The following is a description of a gene set: Any process that modulates the frequency, rate or extent of the covalent alteration of one or more amino acid residues within a protein. Mouse Gene Set: GOBP_REGULATION_OF_PROTEIN_MODIFICATION_PROCESS species: Mus musculus, and this is the list of marker genes: Unc119, Ppia, Smpd3, Slc51b (solute carrier family 51, beta subunit), Bcl2, Cdk2ap1, Lats1, Cdkn1c, Mgat4d, Mapkap1, Garem1, Sh3gl2, Firrm, Ifnar1, Tnik, Atg101, Sez6l2, Nod2 (nucleotide-binding oligomerization domain containing 2), Akap6 (NCBI Gene Id 238161), Gtpbp4, Parp14, Plxnb2, Gstp3, Rabgef1, Fgf18, Pkib, Inpp5k, Lep, Nf2, Camp, Eif2ak3, Snta1, Irgm2, Jak2, Cblc, Fgf4, Prkrip1, Akt1, Abi1, Abca2, Trib2, Cd40, Sfn, Pias1, Rock2, Fam107a, Cdkn2a, Wnk4, Dnajb2, Itch, Adcy8, Pik3r5, Map3k10, Cln3, Prmt3, Tnfrsf18, Tab2, Arhgef2, Ripk3, Gstp1, Egf, Oprd1, Inhba, Ahrr, Pin1, Fiz1, Pkig, Hmga2, Wnk3, Fgf1, Drd2, Rgn, C3, Thbs4, Slc1a1, Epha7, Areg, Fnip2, Ticam1, Ube2v1, Ptpn11, Prickle1, Traf4, Trim44, Pik3r3, Ptpn6, Itgb2l, Cdk12, Arrdc4, Ccnd1, Prkaa1, Il3, Rgs2, Tlr8, Ddx3x (DEAD box helicase 3, X-linked), Gnas, Psen1, Atg13, Hif1a, Kndc1, Cd6, Dnaja1, Cck, Sptbn4, Ceacam1, Plec, Spsb4, Ptgis, Bag5, Wdr24, Bmp2, Gprc5b, Traf3ip1, Hsp90aa1, Peli3, Adra2a, Tlr6, Gps2, Pdcd10, Rab3gap2, Rap2a, Bcar3, Il21, Itln1, Ep300, Adam9, Spn, Tsacc, Casp3, Hyal2, Sh2d1b2, Bag1 (BCL2-associated athanogene 1), Gstp2, Fbxo4, Lrp4, Cspg4 (chondroitin sulfate proteoglycan 4), Dcun1d4, Cib1, Cab39, Hgs, Camkk2, Pard3, Ube2srt (NCBI Gene Id 620508), Cdc37, Stk38, Ptpn13, Cntn1, Cblb, Flt4, Ptprh, Tnfrsf1a, Mir26a-2, Trib3, Epha1, Il13, Bag2, Psen2, Mob2, Dusp10, Magi3, G6pd2, Pip5kl1, Nbn, Snx9, Fn1, Fanci, Ctnnb1, Hnf4a, Ppargc1a, Peli2, Fzr1, Il23a (interleukin 23, alpha subunit p19), Card14, Kdr (NCBI Gene Id 269657), Fbln1 (fibulin 1), Dtx3l, Bmpr2 (bone morphogenetic protein receptor type 2), Ivns1abp (influenza virus NS1A binding protein), Hes1, Tlr4, Gpr39, Macroh2a1, Smg8, Taok1, Fancm, Sesn2, Mlst8, Cd80, Flt1, Lime1, Hes5, Tab1, Ccl5, Itgb2, Cry1, Apoe, Tsc2, Irak1, Rassf5, Tnfsf18, Yeats2, Limch1, Tesk1, Ect2, Tnks1bp1, Dnajc3, Gab1, Blvra, Cenpe, Ins2, Ube2d1, Dip2b, Zfyve28, C9orf72, Bex6, Bccip, Drd4, Vtn, Bmi1, Mad2l2, Thbs1, Spatc1l, Rad50, Htr2b, Wdfy2, Prkar1a, Pttg1ip, Ptpn2, Hamp, Adrb2, Chfr, Ucn, Nf1, Thy1, Ube3a, Psrc1, Pdgfra, Axin2, Spdye4a, Stil, Fbxw7, Emp2, Ang5, Cadm1, Rap2b, Wdr48, Sox4, Vegfc, Aplp2, Laptm5, Gper1, D1Pas1, Ccl19-ps3, Ralb, Hsf1, Usp44, Cdkn2d, Chi3l1, Mmp9, Map2k4, Pdgfa, Socs1, Adcy10, Efna5, Il9r, Arid5a, Pink1, Derl1, Ubxn2a, Epas1, Mt3, Foxf2, Zbed3, Eif4g1, Map3k4, Itgb1bp1, Ripk2, Araf, Hdac3, Xrcc5, Ngf, Arl2bp, Mycbp2, Rit2, Thpo, Cd109, Slfn1, Zgpat, Stub1, Il6, Acp4, Snca, Mapk8ip1, Wnt3a, Tmem102, Dbi, Nop53 (NCBI Gene Id 98700), Klhl31, Rasgrp1, Cx3cl1 (NCBI Gene Id 58173), Ncor2, Tlr9, Ufl1, Grem1, Csf3, Angpt4, Ripk1, Cep295, Rarres2, Ang, Cdc20, Eif2ak4, Prkdc, Chrna7 (NCBI Gene Id 11441, cholinergic receptor, nicotinic, alpha polypeptide 7), Nlrc3, Vegfa, Musk, Ube2k, Hmg20a, Nupr1, Cdkn2c, Peli1, Inava, Epha4, Hpx, Fech, Tnfrsf11a, Pik3r6, Spag9, Adnp, Mir26b, Hexim2, Tlr1, Il7, Arrb1, Nr2f2 (NCBI Gene Id 67192), Nolc1, Acer2, Aimp2, Adra2b, Cul3, Huwe1, Smo, Ptpn5, Slco3a1 (NCBI Gene Id 97427), Adipor2, Nras, Sod1, Ramp1, Avp, Sirt7, Ggnbp2, Cdyl, Lilrb4a, Rnf111, Maged1, Sfrp5, Ccl19-ps6, Ppp4c, Plaur, Inca1, Met, Hhex, Hspa2, Wnt9b, Jun, Tirap, Adam17, Rap1a, Tppp, Kdm4d, Smad7, Birc7, Txn1, Lrp8, Traf6, Dcun1d5, Mastl, Agrn, Il4, 2610042L04Rik, Eef2k, Prkch, Reln, Nos1, Sumf2, Hipk3, Il1b, Tcf25, Irf1, Lrrk2, Map2k6, Nnmt, Reg3b, Pdgfc, Fgf7, Ddr2, Grk2, Cep85, Map3k12, Clcf1 (cardiotrophin-like cytokine factor 1), Fam20a, Eng, Fyn, Ptprj, Sgf29 (NCBI Gene Id 75565), Cav2, Pih1d1, Fzd5, Sh3bp5, Slit2, Brms1 (NCBI Gene Id 107392), Arhgef5, Hmgcr, Mtor, Jtb, Nlrp12, Tm9sf5, Robo1, Sphk1, Slc8a1, Smyd3, Cdk5r1, Il6st, Ccn1, Gnl3, Gata1, Nck1, Mst1r, Pdgfb, Dcun1d2, Klhl40, Prkn, Trpt1, Zfp91, Cnot9, Cdk5, Trib1, Ccl19-ps4, Mrnip, Fbxo7, Wnt1, Nxn, Hcls1, Ifnb1 (NCBI Gene Id 15977), Suz12, Pdcd4, Irgm1, Mre11a, Prr5l (proline rich 5 like), Tspyl2, Rwdd3, Il22ra2, Fgf8, Ropn1, C1qtnf9, Ppp2r5d, Usp4, Ankrd54, Hdac4, Fnip1, Ptger4, Smpd1, Vegfb, Chmp6, Mul1, Phip, Ptprz1, Skp1, Gnaq (NCBI Gene Id 71788), Cops9, Pbk, Gsk3a, Rpl5, Abi3, Insr, Inpp5j, Cacul1, Mob1b, Pdgfd, Vps25, Birc2, Tspan9, Nek3, Hbegf (heparin-binding EGF-like growth factor), Kat2b, Mapk8, Atg5, Gprc5a, Prkcd, Fgd4, Sh2d1b1, Ccnb1, Aif1, Limk1, Ube2s, Wnk1, Parp10, Trim21, Cldn19, Map2k2, Fgd2, Tnip1, Pparg, Npm1, Spink1, Bmp6, Pecam1, Senp2, Nherf1, Lif, Hrg, Cx3cr1, Nrxn1, Pim1, Ndufs4, Mapk1, Bex2, Hsp90ab1, Cav3, Cd3e, Hmgb1, L1cam, Rasip1, Ube2l3, Plk1, Chrna3, Trim27, Tenm1 (NCBI Gene Id 630184), Ube2v2, Ppp5c, Strada, Isg15, Brat1, Cdkn2b, Dab2ip, Crtap, Men1, Hdac8, Ibtk, Rb1 (NCBI Gene Id 19645), Sae1, Icam1, Wfs1, Ndfip2, Mtbp, Crlf1, Ctf1, Mmd, Myocd, Nek10, Dusp3, Tead1, Epo, Daxx, Bdkrb2, Bcl10, Pik3ca, Ptk6, Traf7, Il22, Mta1, Ralbp1, Anxa2, Fgf2, Akap5, Cep63, Osm, Map3k13, Spry2, Raf1, Wdr5, Gpd1l, Ezh2, Trem2, Ccl19, Hdac6, Abl1, Itga5, Braf, Ptpn22, Nox4, Tcim (NCBI Gene Id 69068), Ulk1, Tnk2, Gjc2, Rbx1, Cdk5r2, Dusp6, Ropn1l, Tpx2, Spdya, Insm1, Nfe2, Gsk3b, Ern2, Agt, Prox1, Shb, Adra2c, Ubxn1, Flt3l, Lrrk1, Nscme3l, Csf1r, Nedd9, Ube2n, Hamp2, Adcyap1, Tfrc, Sez6l, Vldlr, Fshr (follicle stimulating hormone receptor), Tspyl5, Ang4, Nsmce3, Mavs, Ccnd2, Topors, Pdcd6, Mapre3, Trabd2b, Enpp1, Ccdc88a, Ighm, Deptor (NCBI Gene Id 97998), Fgfr3, Cnot7, Kirrel1, Ulk4, Btrc, Pla2g6, Chga, Yes1, Ins1, Pebp1, Pik3cg, Terf2ip, Hspbp1, Vangl2, Zeb2, Xrcc6, Fzd8, Phf23, Hspa5, Ppp2r5b (protein phosphatase 2, regulatory subunit B', beta), Prnp, Trim23, Slc8a3, Fzd4, Fkbp8, Ntrk2, Clip3 (CAP-GLY domain containing linker protein 3), Cdc25b, Ltf, Fgf15, Tgfb1, Pik3c3, Rapgef3, Aktip, Tnfrsf14, Edn1, Erbb2, Caml, Iqgap3, Nptn, Tank, Itgb1, Higd1a, Dr1, Samsn1, Oxr1, Dbndd2, Akt1s1, Atg7, Ilk, Pomt1, Kras, Fbn1, Paqr3, Siah2, Osbp, Pkia, Ncam1, Mmd2, Vcp, Fcer1a, Hmg20b, Rasd2, Lilrb4b, Birc3, Gskip, Ang6, Isl1, Clec7a, Psmd10, Igf1, Ptprc (NCBI Gene Id 19264), Pml (promyelocytic leukemia), Ogt, Aspscr1, Ubqln1, Gfra2, Map3k7, Gpnmb, Edn3, Tlr7, Ercc6, Ntf3, Dock7 (NCBI Gene Id 67299), Syap1, Cdk5rap3, Dynapl1, Adgrb1, Odam, Rpl11, Egfr, Synpo2, Csf2, Ppp2r3c (NCBI Gene Id 80481), Ppm1e, Ehmt2, Il12b, Golga2, Erbb4 (erb-b2 receptor tyrosine kinase 4), Lilra5, Pax6, Cdkn1b, Atf2, Ctdspl, Fmr1, Lats2 (NCBI Gene Id 50523), Kirrel2, Adar, Cryaa, Cdh5, Tnfrsf4, Il9, Stox1, Bst1, Tnfaip3, Rbx1-ps, Fgfr1, Rapgef2, Hspa4, Sema4d, Plaa, Ccl19-ps5, Gnl3l, Slc8a2, Wbp1l, Tsc1, Cops8 (NCBI Gene Id 98184), Dynap, Mad2l1, Nelfe, Ptk2, Cadm4, Zzef1, Washc1, Ret, Egr1, Cactin, Trim6, Skp2, Ehd4, Rac1, Ppp1r9b, Gclc, Chek2, Fbxo2, P2ry1, Spry4, U2af2, Ppm1f, Taok3, Tgfb2, Wdr59, Ctdsp2, Ip6k2, Epm2a, Srcin1, Dmtn, Arrdc3, Spred2, Prr5, Dusp19, Stk4, Dusp1, Prom2, Cd300ld3, Ccr7, Akap11, Capn3, Syk, Dlg1, Fgf10, Pkn1, Gstp-ps, Taf7, Tnf, Uchl1, Kat14 (lysine acetyltransferase 14), Crkl, Dcun1d1, Stradb, S1pr2, Pten, Stk11, Rnf40, Htt, Fabp4, Tgfa, Tcl1, Kat5, Trpc6, Xdh, Dkk1, Lrrn3 (NCBI Gene Id 16981), Cdk2ap1rt, Fas, Hspa1b, P2rx7, Igtp, Mas1, Vps28, Cartpt, Ccdc134, Ncl (NCBI Gene Id 319677), Camk1 (calcium/calmodulin-dependent protein kinase I), Notch2, Reg1, Ptprt, Akt2, Iqgap1, Xbp1, Rasa1, Tgfbr1, Arr3, Socs4, Cntf, Bex1, Csf1, Wars1, Hbb-bs, Pak1, Birc5, Sirt2, Fndc1, Cd44, Rgcc, Herpud1, Fxyd1 (NCBI Gene Id 80524), Ang2, Mif, Tom1l1, Pid1, Ednra, Dvl2, Pdcl3, Acvr2a, Lonp1, Uvrag, Inpp5f, Gba1, Lrp6, Slc11a1, Dnaja3, Mprip, Mydgf, Rassf2, Rela, Lck, Adarb1, Rb1cc1, Neurl1a, Hdac2, Nnt, Cldn3, Dtnbp1, Hrc, Fnta, Ttc36, Pfn2, Sox9, Gabarap (gamma-aminobutyric acid receptor associated protein), Arrb2, Map3k11, Ctdsp1, Apc, Tada2a, Mllt1, Hgf, Trpc5, Flt3, Sema7a, Flot1, Ptpn1 (NCBI Gene Id 19246), Ndn, Bank1, Sez6, Fktn, Nppa, Ptger3 (prostaglandin E receptor 3 (subtype EP3)), Ctnnd1, Crebl2 (cAMP responsive element binding protein-like 2), Rab3gap1, Plpp3, Pde5a, Paxip1, Sqstm1, Coro1c, Fer, Prkd1 (protein kinase D1), Svip, Gadd45g, Gas6, Spred1, Nrg1, Tpd52l1, Mapt, Tes3-ps, Il18, Ccar2, Rgs14, Dusp7, Angpt1, Itpkb, Acvr1, Otud4, Rictor, Klf15, Sfrp1, Pard6a, Crh, Bex3 (brain expressed X-linked 3), Rchy1, Fem1a, Bag4, Fzd1, Cemip, Heg1, Irak3, Tbc1d24, Mvp, Adtrp, Kif14 (kinesin family member 14), Cd4, Mapk15, Ager, Niban1, P3h1, Ube2b, Minar1, G6pdx, Erp29, Trim65 (tripartite motif-containing 65), Atg14, Marchf7, Csnk1d, Commd1, Faxdc2, Sh3rf2, Il5, Agap2, Amer1, Sfrp2, Per2, Grk3, Il34, Aida, Il2, Wee2, Map2k1, Bdnf, Rps2, Cd74, Ncoa7, Il24, Prkag2, Xiap, Fgr, Sumo2, Arnt, Rad51 (NCBI Gene Id 99282), Tspo, Dcun1d3, Pabpn1l, Rnf180, Rhoa, Hint2 (NCBI Gene Id 68917), Eif4g3, Atg10, Rabl3, Ednrb (endothelin receptor type B), Igfbp3, Mapk8ip3, Cdc14b, Ppp1r15b, Pxn, Cdon, Cripto, Ptk2b, Dnajc10, Mlxipl, Lepr, Gbp4 (NCBI Gene Id 17472), Akap9, Hhatl, Pycard, Map4k2, Tada3, Rps3 (NCBI Gene Id 52418), Ccny, Ptpro, Cep43, Prkaa2, Ccl19-ps1 (NCBI Gene Id 100861618), Spry1, Cd24a, Ccn2, Il12a, Ddrgk1, Chp1, Nmi, Sprtn, Ntrk3, Ntrk1, Mapk9, Svbp, Ccnyl1, Pak2, Sirt3, Nup62, Sash1, Axin1, Hspb1, Cxcr4, Hax1, Zc3h12a, Eif2ak1, Itgb3, Cass4, Mir26a-1, Htr2a, Il11, Rps7, Qars1, Gadd45b, Cnksr3, Zzz3, Adipoq, Il6ra, Traf2, Dip2a, Fscb, Pibf1, Ajuba, Nhlrc1, Etaa1, Cav1, Enpp2, Bak1, Prkca, Il15, Wwtr1, Efna1, Pias3, Ubb, Bmp4, Src, Impact, Socs5, Ern1, Fbxo5, Celsr3, Zfp592, Hus1, Pomt2 (protein-O-mannosyltransferase 2), Dvl1, Ptprb, Fbxo33, Drd1, Card10, Gadd45a, Rassf1, Rgma, Hras, Cep78, Prkcz, Flcn, Prkcg, Dgkq, F2, Tbx1 (T-box 1), Myadm, Pde4d, Fry, Ksr1, Kitl, Kit, Kdm1a, Dab1, Tollip, Oga, Hipk2, Map3k1, Stat2, Ocln, Limk2, Dab2, Ereg, Bax, Chordc1 (cysteine and histidine rich domain containing 1), Cdkn1a, Blm, Rspo1, Mst1, Sirt1, Ndfip1 (NCBI Gene Id 71674), Bex4, Tnfsf11, Ccnd3, Tek, Ppef2, Park7, Clspn, App, Rpl23, Ttbk1, Rps23rg1, Map3k5, Bdkrb1, Dok7, Pinx1, Aplnr, Nsd1, Prlr, Gfra1, Pin1rt1, Cd300a, Phlpp1, Fbh1, Pdgfrb (NCBI Gene Id 18596), Lyn, Tsg101, Mbip, Pik3r1, Ubash3b, Bmal1, Parp9, Nkx3-1, Uba2, Il31ra, Tfap4, Lox, Ppp2ca, Nelfa, Map2k7, Dvl3, Ifng (NCBI Gene Id 15978), N4bp1, Tardbp, Dusp22, Socs3, Hnf1a, Gdnf, Fam161a, Rap2c, Pias4, Septin4, Prkce, Pef1, Rtraf, Ppp1r15a, Abi2, Dysf, Apoa1, Map2k3, Rack1, Tmed2, Als2 (NCBI Gene Id 77293), Kat2a, Zfp418, Spopl, Tbc1d7, Rptor, Errfi1, Cdk5rap1, Wnt5a